Given this list of marker genes Ube2d1, Mapk3 (mitogen-activated protein kinase 3), Fzr1, Cdkn1b, Anapc2, Cdc23, Ubb, Anapc10, Ehmt1, Cdk4, Cdkn2b, Anapc7, Cdc26, Ube2s, Ube2e1, Ube2c (ubiquitin-conjugating enzyme E2C), Rps27a, Cdkn1a, Mapk7, Ccna1, Anapc15, here is a description of the gene set: This event has been computationally inferred from an event that has been demonstrated in another species.<p>The inference is based on the homology mapping from PANTHER. Briefly, reactions for which all involved PhysicalEntities (in input, output and catalyst) have a mapped orthologue/paralogue (for complexes at least 75% of components must have a mapping) are inferred to the other species. Reactome Pathway: Senescence-Associated Secretory Phenotype (SASP) electronically inferred by orthology from the curated human pathway part of: Cellular Senescence studied in species Mus musculus